Given this list of marker genes Sart3, Tut1, Prpf4, Tex16, Lsm3, Ddx39b (DEAD box helicase 39b), Prpf8, Eif5a, Rbm22, Lsm4, Mettl16, Larp7-ps, Larp7, here is a description of the gene set: studied in species Mus musculus Mouse Gene Set: GOMF_U6_SNRNA_BINDING Binding to a U6 small nuclear RNA (U6 snRNA).